Given this list of marker genes Ccdc47, Ncf2, Arid5a, Mob3a, Mplkip, Ypel1, Grem1, Slc2a6, Ocrl, Inca1, Stard7, Ptpn7, Fbxo45, Ccna2, Icmt, Mmp24, Acvrl1, Lrrc8a, Hoxd13, Evc, Tedc1, Fat4, Gm21992, Cnot6, Vav1, Gtpbp2, Lima1, Snx2, Krtap1-5, Tspan11, Gemin8, Pea15a, Fyco1, Pcsk1n, En2, Mtcl2, Rbm4, Adnp, Cd200r3, Marcksl1, Pkm, Igfbp5, Cadm1, Mmaa, Rsl1d1, Gpr157, Zfp799, Runx1t1, Erbin, Csdc2, Pigh, Map3k9, Traf6 (NCBI Gene Id 99098), Pglyrp2, Melk, Mylk2, Slc12a6, Krr1, Lmx1a, Tsr1 (TSR1 20S rRNA accumulation), Rbm20, Slc6a16, Ubqln4, here is a description of the gene set: studied in species Mus musculus Mouse Gene Set: MIR_378D from publication Chen Y, Wang X (PMID 31504780) Genes predicted to be targets of miRBase v22 microRNA mmu_miR_378d in miRDB v6.0 with MirTarget v4 prediction scores > 80 (high confidence targets).